Given this list of marker genes CD74, PSMD10, PTTG1IP, DYRK1A, MIF, SIRT1, YJU2, CD44, TWIST1, SNAI2, SNAI1, KDM1A, MARCHF7, MDM2, DYRK3, here is a description of the gene set: species: Homo sapiens Any process that stops, prevents, or reduces the frequency, rate or extent of the cascade of processes induced by the cell cycle regulator phosphoprotein p53, or an equivalent protein, in response to the detection of DNA damage. Human Gene Set: GOBP_NEGATIVE_REGULATION_OF_DNA_DAMAGE_RESPONSE_SIGNAL_TRANSDUCTION_BY_P53_CLASS_MEDIATOR